The following is a description of a gene set: The acquisition, loss, or modification of macromolecules within a complex, resulting in the alteration of an existing complex. studied in species Mus musculus Mouse Gene Set: GOBP_PROTEIN_CONTAINING_COMPLEX_REMODELING, and this is the list of marker genes: Pnlip, Lipc, Pltp, Apob, Lpl, Taf8, Pla2g10, Pnliprp1, Apoa2, Pla2g5, Abca5, Gpihbp1, Apom, Nr1h4, Pla2g2e, Apoa1, Apoa5, Abcg1, Mttp, Apoc3, Apoc1 (NCBI Gene Id 11812), Scarb1, Apoa4, Pnliprp2, Apoe, Pla2g12b, Lipg, Lcat (NCBI Gene Id 27968), Diaph3, Mpo, Pla2g7, Pla2g3